The following is a description of a gene set: species: Homo sapiens Cholesterol metabolism with Bloch and Kandutsch-Russell pathways Human Gene Set: WP_CHOLESTEROL_METABOLISM_WITH_BLOCH_AND_KANDUTSCHRUSSELL_PATHWAYS, and this is the list of marker genes: HSD17B7, MVD, SQLE, FADS1, FDFT1, FADS2, SC5D, ELOVL4, SREBF1, ELOVL5, FDPS, HMGCR, DHCR24, ELOVL3, MVK, LBR, GGPS1, CH25H, MYLIP, MSMO1, DHCR7, CYP51A1, ACOT2, ACSL4, ACSL3, CYP27A1, ELOVL2, EBP, ABCA1, TM7SF2, NR1H2, SOAT2, ACSL1, NSDHL, SREBF2, IDI1, ABCG1, HMGCS1, PMVK, SCD, CYP46A1, LSS, ACAT2, SOAT1, FASN, HMGCS2, NR1H3